The following is a description of a gene set: from publication Markey MP, Bergseid J, Bosco EE, Stengel K, Xu H, Mayhew CN, Schwemberger SJ, Braden WA, Jiang Y, Babcock GF, Jegga AG, Aronow BJ, Reed MF, Wang JY, Knudsen ES (PMID 17452985) studied in species Mus musculus Genes up-regulated in MEF cells (embryonic fibroblasts) isolated from RB1 knockout mice: chronic loss of function (LOF) of RB1. Functional inactivation of the retinoblastoma tumor suppressor gene product (RB) is a common event in human cancers. Classically, RB functions to constrain cellular proliferation, and loss of RB is proposed to facilitate the hyperplastic proliferation associated with tumorigenesis. To understand the repertoire of regulatory processes governed by RB, two models of RB loss were utilized to perform microarray analysis. In murine embryonic fibroblasts harboring germline loss of RB, there was a striking deregulation of gene expression, wherein distinct biological pathways were altered. Specifically, genes involved in cell cycle control and classically associated with E2F-dependent gene regulation were upregulated via RB loss. In contrast, a program of gene expression associated with immune function and response to pathogens was significantly downregulated with the loss of RB. To determine the specific influence of RB loss during a defined period and without the possibility of developmental compensation as occurs in embryonic fibroblasts, a second system was employed wherein Rb was acutely knocked out in adult fibroblasts. This model confirmed the distinct regulation of cell cycle and immune modulatory genes through RB loss. Analyses of cis-elements supported the hypothesis that the majority of those genes upregulated with RB loss are regulated via the E2F family of transcription factors. In contrast, those genes whose expression was reduced with the loss of RB harbored different promoter elements. Consistent with these analyses, we found that disruption of E2F-binding function of RB was associated with the upregulation of gene expression. In contrast, cells harboring an RB mutant protein (RB-750F) that retains E2F-binding activity, but is specifically deficient in the association with LXCXE-containing proteins, failed to upregulate these same target genes. However, downregulation of genes involved in immune function was readily observed with disruption of the LXCXE-binding function of RB. Thus, these studies demonstrate that RB plays a significant role in both the positive and negative regulations of transcriptional programs and indicate that loss of RB has distinct biological effects related to both cell cycle control and immune function. Human Gene Set: MARKEY_RB1_CHRONIC_LOF_UP, and this is the list of marker genes: STMN2, ANP32B, FOXP1, CRABP1, TOP2A, RSPO2, NME4, RBL1, DNMT1, ANXA8L1, ACAT2, DNAJC9, MSH2, HSPA1A, PDGFRA, HOXA11, EGR1, MAP3K4, OSMR, GJA1, VCAN, CDCA7, IL1RL1, NAB1, CDK2, ANGPTL2, GATM, SGCD, RFC3, IDI1, SFRP2, TK1, LSS (NCBI Gene Id 4047), PRIM1, RASA3, TPST1, PROS1, CASP2, COL6A3, SLC25A15, ZMYM4, ELOVL6, POLA1, PML, COX6B2, NFIX, CRIP1, TIPIN, XRCC1, CXCL12, WDHD1, CDKN1A, PIGA, PRKG2, UHRF1, SMOC2, KLF4, MCM7, H19, HJURP, ERCC5, GIPC2, SCD, SLK, GAS2, BRCA2, FADS1, SQLE, SLC27A3, CYP51A1, PRDX4, AQP1, EZH2, HOXA11-AS, SCMH1, STMN1, SEMA3F, MAN2A1, CBX2, SLBP, PCNA, DOK1, IDH2, FDFT1, NCAPH, IGF2R, KANK3, MCM2, DNM1, SLC1A5, CBFB, CDCA4, PLTP, ST3GAL4, CYTH3, GATA3, TRIM37, GSR, ANAPC5, KCNN4, CBX6, RAB3B, SIVA1, GPC3, CHAF1B, SDC1, POLD1, PCLO, DNPH1, DKK2, ANGPT2, FAM3C, AGTR2, AREG